The following is a description of a gene set: part of: Extracellular matrix organization Reactome Pathway: Laminin interactions Laminins are a large family of conserved, multidomain trimeric basement membrane proteins. There are many theoretical trimer combinations but only 18 have been described and the existence of isoforms laminin-212 and/or laminin-222 awaits further confirmation. The chains assemble through coiled-coil domains at their C-terminal end. Alpha chains additionally have a large C-terminal globular domain containing five LG subdomains (LG1-5). The N termini are often referred to as the short arms. These have varying numbers of laminin-type epidermal growth factor-like (LE) repeats. Trimer assembly is controlled by highly specific coiled-coil interactions. Some laminin isoforms are modified extracellularly by proteolytic processing at the N- or C-terminal ends prior to their binding to cellular receptors or other matrix molecules (Tzu & Marinkovitch 2008).<br><br>The cell adhesion properties of laminins are mediated primarily through the alpha chain G domain to integrins, dystroglycan, Lutheran glycoprotein, or sulfated glycolipids. The N-terminal globular domains of the alpha-1 and alpha-2 chains and globular domains VI (Nielsen & Yamada 2001) and IVa (Sasaki & Timpl 2001) of the alpha-5 chain can bind to several integrin isoforms (alpha1beta1, alpha2beta1, alpha3beta1, and alphaVbeta3), which enables cell binding at both ends of laminins with these alpha chains. species: Homo sapiens, and this is the list of marker genes: LAMA5, ITGA7, COL4A5, HSPG2, ITGB4, COL7A1, LAMA4, COL4A3, LAMC1, ITGA3, ITGA2, COL4A1, ITGA1 (NCBI Gene Id 3672), COL4A4, LAMA1, COL4A6, ITGAV, LAMB2, LAMC3, LAMC2, LAMA2, COL4A2, NID1, ITGB1, LAMB1, LAMB3, LAMA3, COL18A1, ITGA6 (integrin subunit alpha 6), NID2